Given this list of marker genes CYP2J2, GSTP1, CYP2C9, COX8A, CYP2C8, COX5A, EPHX2 (epoxide hydrolase 2), here is a description of the gene set: species: Homo sapiens Human Gene Set: WP_ARACHIDONATE_EPOXYGENASE_EPOXIDE_HYDROLASE Arachidonate epoxygenase / epoxide hydrolase